The following is a description of a gene set: species: Homo sapiens Human Gene Set: HP_ANTI_SMOOTH_MUSCLE_ANTIBODY_POSITIVITY Anti-smooth muscle antibody positivity The presence in serum of antibodies against smooth muscle., and this is the list of marker genes: COL4A5, FAS, CD247, COL4A6, FASLG, ITCH, CASP10, DOCK11